The following is a description of a gene set: from publication Boylan KL, Gosse MA, Staggs SE, Janz S, Grindle S, Kansas GS, Van Ness BG (PMID 17483317) Multiple myeloma is an incurable plasma cell malignancy for which existing animal models are limited. We have previously shown that the targeted expression of the transgenes c-Myc and Bcl-X(L) in murine plasma cells produces malignancy that displays features of human myeloma, such as localization of tumor cells to the bone marrow and lytic bone lesions. We have isolated and characterized in vitro cultures and adoptive transfers of tumors from Bcl-xl/Myc transgenic mice. Tumors have a plasmablastic morphology and variable expression of CD138, CD45, CD38, and CD19. Spectral karyotyping analysis of metaphase chromosomes from primary tumor cell cultures shows that the Bcl-xl/Myc tumors contain a variety of chromosomal abnormalities, including trisomies, translocations, and deletions. The most frequently aberrant chromosomes are 12 and 16. Three sites for recurring translocations were also identified on chromosomes 4D, 12F, and 16C. Gene expression profiling was used to identify differences in gene expression between tumor cells and normal plasma cells (NPC) and to cluster the tumors into two groups (tumor groups C and D), with distinct gene expression profiles. Four hundred and ninety-five genes were significantly different between both tumor groups and NPCs, whereas genes were uniquely different from NPCs in tumor group C and genes were uniquely different from NPCs in tumor group D. Similar to human myeloma, the cyclin D genes are differentially dysregulated in the mouse tumor groups. These data suggest the Bcl-xl/Myc tumors are similar to a subset of plasmablastic human myelomas and provide insight into the specific genes and pathways underlying the human disease. Mouse Gene Set: BOYLAN_MULTIPLE_MYELOMA_PCA3_DN studied in species Mus musculus Top down-regulated genes from principal component 3 (PCA3) which captures variation among different plasma cell tumors arising from overexpression of BCL2L1 and MYC., and this is the list of marker genes: Lxn, Apc, Stk3, Wfdc21, Ggta1, Igkv1-117, Tmem141, Crybg1, Rsph9, Ddx3y, Apobec2 (apolipoprotein B mRNA editing enzyme, catalytic polypeptide 2), Dennd4c, Gas7, Casp7, Abhd8, Sh3bp1, Eci2, Arhgap21, Phka1, Anxa4, Kndc1, Casp1, Prm1, Rsph1, Marcks, Upb1, Med9os, Heatr5b, Lifr, Zcchc14, Pcbp4, Zfp799, Hsd17b13, Ipcef1, Ehhadh, Atp11a, St3gal5, Il7r, Nxpe2, Adam19, Asb2, Rag1, Cyth4, Zfp975, Skp2, Ctnna1 (catenin alpha 1), Gm46430, Gsdmd, Top2b, Hoxc4, Iglc1, Rdx, Flot2, Slc15a2, Rin3, Myl9, Bst1, Dnm1l, Eif2s3y, Suclg2, Stom, B3gnt8, Tspan2, Reln, Tifab, Ceacam1, Ptgr1, Ccnd3, Zbed4, Tnni2, Cysltr1, Capsl, Gsn, Cstf2t, Iglv1